The following is a description of a gene set: Human Gene Set: GOBP_MONOATOMIC_CATION_TRANSPORT The directed movement of a monoatomic cation, into, out of or within a cell, or between cells, by means of some agent such as a transporter or pore. Monatomic cations (also called simple cations) are positively charged ions consisting of exactly one atom. studied in species Homo sapiens, and this is the list of marker genes: GRIN2A, AHCYL1, GJA5, CACNA2D3, CHRNA4, NDUFB8, SLC22A5, PRKACA, ATP6V0C, ATP6V0D2, GNAI2, ATP1B2, TMSB4X, UQCR10, AKAP6, SCN10A, LRRC26, SCNN1A, ANK3, SLC30A6, SELENON, GAL, MIR29B1, CD84, MAGED2, AKT1, MIR208B, SLC36A1, CD4, CALHM2, TMEM63A (transmembrane protein 63A), MRLN, SLC13A5, NDUFA7, NPPA, ATP6V1C2, WNK2, SLC22A4, P2RX3, LPAR3, CNGA2, SLC30A10, CX3CL1, NDUFS3, SLC23A1, EPB41, SLC24A1, VPS4B, PKD1L1, SURF1 (NCBI Gene Id 6834), SLC30A4 (NCBI Gene Id 7782), ATP2B3, ATP6V0A4 (ATPase H+ transporting V0 subunit a4), NDUFS6, GRIN2C, SCN2A, NDUFA2, PIEZO2, PPP3CA, MT-CO3, PER1 (NCBI Gene Id 5187), FGF2, ANXA6, RGS4, KCNIP4, KCNJ8, DDIT3, SLC30A3, SLC31A2, CACNB4, SLC18A2, FXYD2, SLC4A4, NDUFC2, ISL1, LARGE1, KCNK12, HRC, CASK, PLCB1, BSPRY, KEL, TOR2A, SLC32A1, MT-ATP8, SCN11A, TMEM38A, ATP6V0A2, CACNA1E, SLN, HES1, LETM1, SHROOM2, NOS1, FASLG, SLC6A9, SLC39A7, DMPK, NSF, LACRT, NDUFB3, ATP6V0D1, KCNRG, F2R, NALF1, BEST1, CATSPER4, FXYD5, XCL1, CASQ2, ATP5MC1, NDUFA3, NDFIP1, KCNS1, KIF5B, CACNA2D1, SGK1, KCNJ14, ABCC9, NTSR1, VMP1, ATP5F1EP2, HPX, ATP1A4, KCNIP1, STIMATE, FKBP1B, FMR1, SLC12A9, MT-ND1, KCNV2 (potassium voltage-gated channel modifier subfamily V member 2), SCN9A, CAV1, FCRL3, TRPC6, NDUFV2, HCN3, ATP6V0E2, SLC17A8, GP1BA, RGS9, KCNH1, CATSPER2 (cation channel sperm associated 2), KCNH8, CALHM1, SLC6A5, GPR35, SLC39A9, CCL5 (NCBI Gene Id 8147), PLCH1, SARAF, SLC25A13, SLC5A12, TRPC4, EDN1, KCNH2, KCNK7, TSC1, MIR24-1, CSN2, MS4A1, SCNN1G, SLC8A2, FXYD3, TMX1, COX7A2L, KCND2, PIK3CG, CYSLTR1, STAC3, RCVRN, TRPC3, ATP2C1, OTOP3 (NCBI Gene Id 347741), MCOLN2, KLHL3 (kelch like family member 3), SLC38A5, SLC5A5, MIR34A, COMMD1, ATP6V1G1, SCN4A, MMP9, WFS1, CLTC, NDUFB2, SLC9A9, CAV3, SLC12A6, MCOLN3, OPRK1, CREB3, CXCR3, KCNMA1, CACNA1B, CACNA1D, FLVCR2 (NCBI Gene Id 55640), PLCL1, ATP12A, KCNQ3, KCNU1, LETM2, SLC13A3, RAB11B, KCNN2, SCN2B, ACTN4, GRINA, STING1, SLC6A8, F2, CDKN1B, FTH1P19, ATP6V1D, KCNH7, ATP5PF, KCNH4, PRKCE, KCNK18, NDUFS4, SLC25A18, KCNAB3, CCL3, MIR212, ATP5F1A, GHITM (growth hormone inducible transmembrane protein), HCN2, EPO, ATP6V1E1, KCNH5, KCNA2, AQP1, KCNH3, MIR448, BCL2, ATP6V0A1, SLC9C2, ATP13A4, SLC5A1, TLR9, NKAIN1, PSEN2, CACNG6 (NCBI Gene Id 59285), SLC30A1, ATP4A, GPD1L, CXCL9, PDE4D, STEAP2, SLC48A1, SFXN1, METTL21C, CALHM3, SLC17A5, CALCRL (calcitonin receptor like receptor), NIPA2 (NIPA magnesium transporter 2), MIR210, PTPN6, PDE4B, SLC18A3, TUSC3, SLC5A2, HAP1, SLC29A4, PLA2G1B, SCN1A, CAB39 (calcium binding protein 39), GUCA2B, KCNS3, SLC25A27, HOMER3, CACNB1, ABCB8, SLC4A5, KCNJ3, ATP5PD, DNM1L, SLC13A4, SERPINE2, SLMAP, NIPAL3, ADRB2, PON3, TRPM8, SLC38A11, ATP5F1D, CACNG2, CDH23, TPCN2, AHNAK, HOMER1, ZMPSTE24, COX4I1, SPINK1, PLCB2, UTRN, COX6B1, SLC4A11, ATP6V1G2, PKD2L2, ASIC5, TMEM94, CRHR1, NCS1 (neuronal calcium sensor 1), NDUFS8, BHLHA15, HTR2C, MT-ATP6, CACNG4, RNASEK, BPIFA1, ATP5MC2, B2M, SLC10A5, MICU2, PRKD1, WNK3, TMEM150C, LCK, COX7A1, MAIP1, NDUFB6, CRACR2A, CAMK2D, COX17, SLC6A2, SLC15A4, DLG1, SLC15A3, TFRC, TREM2, STC1, SLC17A6, SLC25A4, CALM3, P2RX6, KCNK5, MYLK, KCNK15, SLC11A2, SLC36A3, NNT, SLC4A8, ADCYAP1R1, VDR, SLC15A1, CYP27B1, SLC8A3, ATP6AP1, CCL8, ANO9, KCNIP2, KCNA1, AMIGO1 (NCBI Gene Id 57463), SLC11A1, CACNA1C, ATP1A1, BAK1, CD19, SLC13A2, SLC12A7, CHRNB1, PLCB4, PRKCB, KCNA5, SCN4B, WWP2, FTH1 (ferritin heavy chain 1), KCNJ12, FTMT, TF, LRP2, SLC6A11, CACNA1A, DIAPH1, ANK2, ATP6AP2, GRIN2B, SLC30A2, P2RX4, NDUFA8, TMEM38B (transmembrane protein 38B, NCBI Gene Id 55151), KCNQ5, SLC9A1, FXYD7 (NCBI Gene Id 53822), TMBIM4, MIR133A1, KCNQ2, CTNNB1, SLC10A6, SLC39A3, KCNJ10, SLC3A2, KCNA4, SLC9A5, G6PD, SLC30A9, ATP5F1E, CALHM6, YWHAE, SLC6A12, NOS3, TSPAN13, TMCO1, RAMP1, TPCN1 (two pore segment channel 1), GRXCR1, SLC40A1, NDUFB1, CYBA, BEST2, PSEN1, SLC39A10, ATP6V0E1, LILRB1, NDUFA10, CHRNB2, SLC39A8, ATP5ME, TRPC1, SLC24A3, SLC16A1, MT-ND5, PGRMC2, SLC30A5, TCN1, CORO1A, PLCG2, SLC25A25, GRP, KCNJ4, KCNE3, SLC12A8, NDUFA4, CACNG3, ZACN, NDUFS5, SLC8B1, FKBP1A, STIM1, SLC5A7, MIR192, CXCL11, SLC39A2, CTNS, CACNA1S, ATP1A2, SLC5A4, MIR30D, MYB (NCBI Gene Id 4602), ADORA2A, KCNQ1, SRI, KCNMB2, SMDT1, PKD1L3, HTR2A (5-hydroxytryptamine receptor 2A), NDUFS7, SLC18A1, CALM2, NIPSNAP2, SLC5A11, UQCRFS1, PANX2, SLC17A1, OXSR1, SLC18B1, SLC17A3, ATP6V1H, PKD2L1, UCP1, STK39, ANO1, CBARP, GRIN3A, CBLIF, SLC30A8, SLC35G1, HCN1 (hyperpolarization activated cyclic nucleotide gated potassium channel 1), ATP2A1, CNGA4, SLC6A7, FLNA, SPHK2, SLC5A3, SNAP25, GCK, ABCB7, STEAP3, NDUFV3, FFAR1, CASR, F2RL3, KCNK4 (NCBI Gene Id 50801), PANX3, CLDN16, CHD7, ASIC4, STAC (NCBI Gene Id 6769), FHL1, KCNJ6, SLC4A7, SCN3B, NDUFS1, DRD1, FGF12, CUL5, PDPK1, TRPM6, TMEM63B, SELENOK, TRPV1, KCNC2, NDUFB5, SLC39A4, CD63, TMBIM6, FTHL17, SLC28A3, FAIM2 (Fas apoptotic inhibitory molecule 2), KCNF1, AGT (angiotensinogen), NKX2-5, OPRM1, LILRA2, MT-ND4, SCN3A, FLVCR1, ITPR1, KCNE5, HPCA, ATG5 (autophagy related 5), KCNJ18, CASQ1, DNM2, CACNA2D4, MIR1-1, MIR21, CEMIP, KCNIP3, JPH3, PTK2B, KCND1, TCN2, REP15, COX5B, UQCRFS1P1, SLC5A10, TMEM109, ATP5F1C, NDUFS2, TRPV3, CCL4, SLC6A4, OSR1, TRPM3, EDN3, SLC39A13, ATF4, ATP5F1B (ATP synthase F1 subunit beta), MIR93, TRPM1, SLC36A2, SLC38A3, TTYH1, SLC2A9, LRRC55, SLC34A1, KCNK10, SLC12A2, CDK2, ATP7B, ATP10D, ATP6V1B2, MT-ND6, SLC34A2, SLC17A2, MCUB, UCN, PPP3CB, TRPV4, NDUFB10, SLC34A3, AP3D1, SLC6A6, ATP13A2, SLC47A1, TRPV2, RAMP3, KCNG1, MIR200C, UQCRH, SLC22A1, SLC30A7, SLC22A2, KCNK1, CAPN3, KCNN4, TMEM63C, SCNN1B, SLC9A8, ACTN2, ATP5PO, NDUFV1, FYN, PRSS8, THY1, CNGB1, TPT1, EDNRB, ITGAV, SLC10A1, CNGB3, VDAC1, NECTIN1, OTOP2, ABCC5, NOS1AP, KCNG4, CCR7, PDGFRB, TFR2, ATP2C2, GNB2, SLC20A2, DMAC2L, KCNA3, P2RX2, SLC6A16, KCNE2, COX5A, PTPRC, ABL1, MIR424, MICU1, GRAMD2A, UBR3, PLCB3, CACNA1I, CCR5, ATOX1, CYC1, SLC39A6, TMEM37, DPP10, FXYD1, AFG3L2, SLC5A8, MLLT6, SLC24A5, KCNJ11, ABCC8, OPRD1, KCNA6, RYR3, MCOLN1, ATP4B, CNGA1, CACNB2, TMEM163, TMCO3, ATP6V1B1, ATP6V1A, PACSIN3, TMEM175, YWHAH, SLC17A7, ANO10, KCNC1, ATP5PB, SLC1A1, SLC39A14, SLC9B2, SLC17A4, CALM1, CRH, ATP5MC3, SLC10A7, SLC12A3, CHRNA9, ARHGAP1, PKD1, NEDD4 (NEDD4 E3 ubiquitin protein ligase), MIR26A1, SLC13A1, NPSR1, CHRNA10, ATP2B2 (ATPase plasma membrane Ca2+ transporting 2), KCNMB4, RAMP2, PKDREJ, SIK1, SLC23A2, AKAP5, GSTM2, ATP5MG, SLC10A4, SLC25A5, PKP2, ADRA2A, P2RX1, DHRS7C, PLCZ1, HAMP, IFNG, ATP1B3, TRPV6, CCL19, CACNA1H, HEPHL1, CTSS, HFE, ATP6V1E2, ROMO1, CALHM5, SCN7A, NDUFB7, SLC25A3, IBTK, SLC5A6, SLC9B1P1, SLC38A4 (NCBI Gene Id 55089), ATP1A3, HCN4, STC2 (stanniocalcin 2), TRPM4, ORAI1, CNGA3, SUMO1, GALR2, SLC10A2, MIR499A, ATP2B1, SLC24A4, CACNA1F, NIPAL2, NDUFA6, TMC1, NDFIP2 (NCBI Gene Id 54602), COX7B, CUTC, TESC, SLC8A1, CHP1, KCNK3, FXYD6P3, LILRB2, SLC46A1, KCNAB1, MIR328, ITPRIPL1, TRPC4AP, WNK4, TRPM2, GP1BB (NCBI Gene Id 89199), GRIN1, CACNB3, CACNA2D2, CATSPER3, TRPC7, MMGT1, RANGRF, MT-ND2, UCP3, CCR1, STRIT1, COMMD3, COX8A, SLC4A10, SLC38A7, SLC12A1, CHRNA1, HEPH, PANX1, KCNA10, UNC80, IL16, AKAP7, KCNK9, CNNM4, CALCA, TSPO, STEAP4, APP, SLC41A1, GRM6, ISCU, MICU3, NALF2, JPH1, CACHD1, PIEZO1, MCHR1, NIPAL1, GP5, PPP3R1, TRPM5, CCT8L2, ASIC1, IL13, SLC24A2, DPP6, SLC6A13, GRIN3B, XCR1, PLCE1 (NCBI Gene Id 51196), CACNA1G, TMBIM1, EGF, ANO6, MAGT1, EDNRA (endothelin receptor type A), ADORA1, LTF, KCNE4, SLC9A4, SLC6A3 (NCBI Gene Id 6531), LCN2, SLC25A28, CCL2, MT-ND3, SLC6A14, SLC41A3 (solute carrier family 41 member 3), TRPM7, KCNT1, HVCN1, WNK1, ORAI2 (NCBI Gene Id 84917), MT-CO2, SLC25A14, CLCN7, CAMK2G, STAC2, CCDC51, EPPIN, NDUFA12, TRPV5, ATP1B1, ATP6V0B, SLC15A2, KCNAB2, KCNN1, GNB5 (G protein subunit beta 5), CLCNKB, ATP1B4, ATP8A1, TRPC5, CHRNA7, TMC2, REM1, UQCRC1, CACNG8, MCU, ABCB6, ATP6V1C1, ATP2B4, TMEM165, SLC25A23, CAMK2A, SLC25A37, HOMER2, NDUFC1, SLC9B1, NDUFB9, RYR1, KCNJ15, SCN5A, SPG11, NKAIN3, KCNB1, KCNJ13, SLC47A2, CXCL12, ATP5MF, WNT3A, SLC39A12, BAX, LILRA5, RYR2, HSPA9, KCNK6, GAS6, KCNK16, PLPP4, FTL, SEC61A1, ATPSCKMT, GCG, MT-ND4L, GPER1, KCNJ2, SLC9A6, LMTK2, SLC1A3, CNKSR3, KCNV1, LYN, CNNM2, JPH2, BIN1, KCNJ9, GSTO1, SLC39A11, UBASH3B, ITPR3, KCNQ4, ASPH, ASIC3, PCSK9, CACNG7, CALHM4, MCUR1, KCNK2, KCNJ16, SLC6A15, TGFB1, MELTF, SLC9A3, KCNJ5, SLC38A1, PML, ATP13A3, MT-CYB, ATP2A2, TRPA1, KCNE1, TCIRG1, KCNC3, UCP2, STIM2, VAMP2, SLC9A2, PMPCB, KCNJ1, ERO1A, SCARA5, SLC39A1, APLNR, LRRC52, GRIA2, PDGFB, CRACR2B, EFHB, BDKRB1, ORAI3, PPIF, NDUFB4, PKD2, ATP7A, NGF, ASIC2, LIME1, SLC5A9, NDUFA5, SLC6A18 (solute carrier family 6 member 18), ITGB3, KCNMB1, SLC25A12, ATP6V1F, SNCA, DRD3 (dopamine receptor D3), CACNG5, NOL3, PLCH2, SLC46A3, NKAIN2, TRDN, HPN, PRNP, CXCL10, GP9, P2RX5, CACNG1, PLCG1, SCNN1D, SCN8A, KCNC4, SPTBN4, GPM6A, ATP6V1G3, KCNMB3, HCRT, SLC12A5, CNTN1, FKBP4, KCNK13, MIR103A1, SPG7, SEMG1, FGF13, SLC39A5, MT-CO1, SLC31A1 (solute carrier family 31 member 1), TRIM27, NKAIN4 (NCBI Gene Id 128414), SLC6A20, ITPR2, MRS2, SLC2A10, SLC9C1, KCNK17, COMMD9, CHRND, LGALS3, CLCN3, P2RX7, INPP5K, KCND3 (potassium voltage-gated channel subfamily D member 3), SLC25A22, SESTD1, SLC4A9, KCNS2, FXYD4, PTPN3, NDUFA1, NEDD4L, SLC20A1, SLC6A19, DMD, LRRC38, ATP5MGL, CHRNE, KCNG3, SLC6A1, MIR208A, EPM2A, KCNG2, PPP3CC, MFSD4B, ZDHHC13, SLC38A2, CHERP, PPP3R2, FXYD6, PKD1L2, PHB2, NDUFA9, SRL, HTR2B, FXN, CLCA1, CATSPER1, SLC6A17, UMOD, SLC9A7 (NCBI Gene Id 84679), CDK5, DRD2, CYBRD1 (NCBI Gene Id 79901), ATP13A1, ATP2A3, JPH4, P2RY6, OTOP1, MT3, KCNA7, KCNH6, NALCN, PLN, KCNB2, KCNN3, HTT, CLIC2 (chloride intracellular channel 2), SCN1B, GRIN2D, NIPA1, KCNT2, SNTA1, SLC12A4, CAMK2B, SLC41A2, NHERF1, NOX5, NIPAL4, ATP13A5, PLCL2, MTCO2P12, UBQLN1, SLC22A17, CCL21